Given this list of marker genes Pax2, Foxc1, Tgfbr3, Bmp7, Pax8, Wt1, Foxc2, Hnf1b, here is a description of the gene set: Mouse Gene Set: GOBP_NEGATIVE_REGULATION_OF_APOPTOTIC_PROCESS_INVOLVED_IN_DEVELOPMENT studied in species Mus musculus Any process that stops, prevents or reduces the frequency, rate or extent of apoptotic process involved in development.